The following is a description of a gene set: The chemical reactions and pathways involving serotonin (5-hydroxytryptamine), a monoamine neurotransmitter occurring in the peripheral and central nervous systems, also having hormonal properties. studied in species Homo sapiens Human Gene Set: GOBP_SEROTONIN_METABOLIC_PROCESS, and this is the list of marker genes: ALDH2, SRD5A1, TPH1, ATP7A, SULT1A3, PDE1B, DDC, HTR1A, SULT1A4, RNF180, TPH2, BTBD9, GRIN2A